Given this list of marker genes Jak3, Cd24a, Il4 (NCBI Gene Id 16189), Il12b, Ppp3ca, Icosl, Igf2, Hmgb1, Il18, Gpam, Epo, Tnfsf4, Rps3, Igf1, Igfbp2, Slamf1, Tnfsf9, Il2ra, Fadd, Il23a (NCBI Gene Id 83430), Pycard, Stat5a, Il12rb1, Cd86 (CD86 antigen), Stat5b, Ager, Il2, here is a description of the gene set: species: Mus musculus Mouse Gene Set: GOBP_POSITIVE_REGULATION_OF_ACTIVATED_T_CELL_PROLIFERATION Any process that activates or increases the rate or extent of activated T cell proliferation.